Given this list of marker genes ETV5, PICK1, TNFAIP6, ITGAL, CDH2, CRK, FLNA, GRIPAP1, SLC7A11, ITGB7, RELN, COLQ, LRP4, NRXN2, MESD (NCBI Gene Id 23184), SSNA1, ITGB2, SSH1, GPHN, DLG3, CRKL, RAC1, SHISA7, FRRS1L, DLG2, DOK7, CHRDL1, MAGI2, CD81, MADCAM1, AGRN, GSN, GRIK2, SCRIB, SLITRK3, LRRC7, NME7 (NCBI Gene Id 29922), FZD9, THY1, ZDHHC2, CD53, RER1, SYNGAP1, NLGN2, APOE, FARP1, SHISA6, NLGN1, DVL1, DLG1, PTN, GLRB, MUSK, SHANK3, FNTA, RAPSN, ITGB1BP1, DLG4, LHFPL4, PIGR, ITGA4, NRXN1, WDR19 (WD repeat domain 19), CDK5, DNAJA3, here is a description of the gene set: species: Homo sapiens Human Gene Set: GOBP_RECEPTOR_CLUSTERING The receptor metabolic process that results in grouping of a set of receptors at a cellular location, often to amplify the sensitivity of a signaling response.